Given this list of marker genes Slc17a7, Picalm, Atp6v0c, Atp6v1b1, Atp6v0a4, Atp6v1e1, Rab3a, Zdhhc2, Atp6v1h, Slc9a6, Atp6v1d, Atp6v1f, Zdhhc20, Atp6v1b2, Atp6v1a, Atp6v0e2, Atp6v1g1, Clcn3, Zdhhc15, Atp6v1g2, Atp6ap2, Atp6ap1, Atp6v0d1, Atp6v1c1, Unc13a, Dlg4, Stxbp1 (syntaxin binding protein 1), Atp6v1g3, Snapin, Atp6v0a1 (NCBI Gene Id 11975), here is a description of the gene set: Mouse Gene Set: GOBP_SYNAPTIC_VESICLE_MATURATION Steps required to form an initiated synaptic vesicle into a fully formed and transmissible synaptic vesicle. species: Mus musculus